The following is a description of a gene set: Mouse Gene Set: REACTOME_ACTIVATION_OF_THE_MRNA_UPON_BINDING_OF_THE_CAP_BINDING_COMPLEX_AND_EIFS_AND_SUBSEQUENT_BINDING_TO_43S studied in species Mus musculus Activation of the mRNA upon binding of the cap-binding complex and eIFs, and subsequent binding to 43S, and this is the list of marker genes: Rps13, Rps3, Eif3i, Eif4a1, Rps23, Eif3e, Eif3d (eukaryotic translation initiation factor 3, subunit D), Rps14, Eif3b, Eif3j2, Rps15a, Eif3k, Rps15, Rps3a1, Rps21, Rps25, Eif4a2, Eif2s2, Eif2s3x, Rps26, Eif3h, Eif3g, Rps5, Rps4x, Rps17, Rps11 (NCBI Gene Id 27207), Eif3j1, Eif3c, Rps29 (NCBI Gene Id 328119), Rps16, Eif2s1, Rps28, Rps27rt, Rps18, Eif3m, Fau, Rps19, Eif4g1, Rps10, Rpsa, Rps8, Rps6 (ribosomal protein S6), Rps27a, Eif3f, Rps27l, Rps9, Rps27, Rps20, Pabpc1, Eif4h, Rps24, Rps7, Eif4b, Eif1ax, Rps12, Eif4ebp1, Eif3a, Rps2 (NCBI Gene Id 16898), Eif4e, Eif3l